Given this list of marker genes TEFM, SHMT2, CBFA2T3, FLCN, ABCD1, DDIT4, UQCC2, GPD1, CHCHD2 (NCBI Gene Id 92547), ALDOB, RHOA, DYRK2, ARL2 (ADP ribosylation factor like GTPase 2), PINK1, MLXIPL, PPP2CA, TP53, TRPV4, ENSG00000293600, RPTOR, DNAJC15, PPIF, EPM2AIP1, RBPJ, ENPP1, OAS1, PARK7, SORBS1, HDAC4, MIR195, PTH, OGT, SLC2A6, INS, PPP1R3C, IRS2, MACROH2A1 (macroH2A.1 histone), ATP7A, PRKAA1 (NCBI Gene Id 5562), PIK3CA, HIF1A, SNCA, PRXL2C, PPP1R3F, MIR210, RUBCNL, NOS2, PNPT1, APP, SLC4A1, IFNG, P2RX7, INPP5K, PRKACA, GAPDHS, PRKAA2, IFNLR1, FBP1, SELENOS, GSK3B, ACTN3, EIF6, PRELID1, MLST8, SLC4A4, PPP1R3D, OPN3, PPP1R3A, TMEM135, CCNB1, MTOR, MLDHR, TREX1, STAT3, GIT1, SRC, PPP1R3E, HTR2A, PRKAG2, GCK, KHK, EP300, TRAP1, SIRT6, MIR1271, PHKA1, AK4, AKT2, PHLDA2, PSEN1, UCHL1, GSK3A, PRKAG3, IGF2, POMC, HMGB1 (high mobility group box 1), PASK, ZBTB20, CAVIN3, JMJD8, CDK1, PHKG2, PPP1R3B, NOP53, ZBTB7A, TIGAR, ADCY10, MTCH2, SIRT3, VCP, SLC25A33, PFKFB1, IDE, NCOR1, NUPR1, TRIM63, ETFRF1, PPP1CA, GHITM, MIR15B, TNF, CISD1, IL4, PRKAG1, ISCU, AKT1, IGF1, PPARA, ARNT, IRS1, IFNAR1, IL10RB, GRB10, IER3, SLC25A23, PRDM16, INSR, GCGR, KAT2B (lysine acetyltransferase 2B), CXXC5, PPP1R3G, here is a description of the gene set: Any process that modulates the frequency, rate or extent of the chemical reactions and pathways resulting in the formation of precursor metabolites, substances from which energy is derived, and the processes involved in the liberation of energy from these substances. Human Gene Set: GOBP_REGULATION_OF_GENERATION_OF_PRECURSOR_METABOLITES_AND_ENERGY studied in species Homo sapiens